Given this list of marker genes Pik3r3, Syk, Pik3cd, Hck, Ubc, Grb2 (growth factor receptor bound protein 2), Vav1, Ubb, Pik3r1, Fyn, Pik3ca, Pik3r2, Lyn, Yes1, Crk, Cbl, Rapgef1, Rps27a, Uba52rt, Crkl, Uba52, Pik3cb, here is a description of the gene set: Regulation of signaling by CBL Mouse Gene Set: REACTOME_REGULATION_OF_SIGNALING_BY_CBL studied in species Mus musculus